The following is a description of a gene set: Hepatoblastoma, the most common pediatric liver cancer, is tightly linked to excessive Wnt/beta-catenin signaling. Here, we used microarray analysis to identify two tumor subclasses resembling distinct phases of liver development and a discriminating 16-gene signature. beta-catenin activated different transcriptional programs in the two tumor types, with distinctive expression of hepatic stem/progenitor markers in immature tumors. This highly proliferating subclass was typified by gains of chromosomes 8q and 2p and upregulated Myc signaling. Myc-induced hepatoblastoma-like tumors in mice strikingly resembled the human immature subtype, and Myc downregulation in hepatoblastoma cells impaired tumorigenesis in vivo. Remarkably, the 16-gene signature discriminated invasive and metastatic hepatoblastomas and predicted prognosis with high accuracy. species: Homo sapiens from publication Cairo S, Armengol C, De Reyniès A, Wei Y, Thomas E, Renard CA, Goga A, Balakrishnan A, Semeraro M, Gresh L, Pontoglio M, Strick-Marchand H, Levillayer F, Nouet Y, Rickman D, Gauthier F, Branchereau S, Brugières L, Laithier V, Bouvier R, Boman F, Basso G, Michiels JF, Hofman P, Arbez-Gindre F, Jouan H, Rousselet-Chapeau MC, Berrebi D, Marcellin L, Plenat F, Zachar D, Joubert M, Selves J, Pasquier D, Bioulac-Sage P, Grotzer M, Childs M, Fabre M, Buendia MA (PMID 19061838) Human Gene Set: CAIRO_HEPATOBLASTOMA_CLASSES_UP Genes up-regulated in robust Cluster 2 (rC2) of hepatoblastoma samples compared to those in the robust Cluster 1 (rC1)., and this is the list of marker genes: OXA1L, DCP2, RPL23, RUVBL2, EIF4E2, AK4, DNAJC4, PQBP1, POLR3E, SLC25A3, BSG, CCT3, POLD1, CERS6, PAXIP1, TUBG1, DNAAF5, NLE1, HNRNPA3P1, SMARCC1, PDIA6, PUS7, DDX18, SNHG14, PABPC4, EIF3H, SEC61G, RFXANK, KIF20A, UTP18, CCNA2, MEP1A, PFAS, R3HDM1, P3H4, B9D1 (B9 domain containing 1), CCT4, IPO5, PUS1, ZC3H15, MCM4, COPS5, RPS21, CSE1L, CKS2, CLNS1A, AGBL5, CHEK1, EIF3F, PSMF1, WDR3, LRRC59, SF3A1, ARFGEF1, CSNK2B, HMGA2, TRAP1, IL1RAPL1, MNAT1, TOMM70, VTI1B, YBX3, MRPS7, PRMT1, NSD2, BORA, PARP1, SNRPB, TCERG1, LANCL2, NUP210, EXOSC4, DNAJC7, GPS1 (G protein pathway suppressor 1), AHCY, NME2, SMC2, TRRAP, GCFC2, HDAC2, CREB3L2, FAM136A, TTK, NAT10, ZNF696, ESF1, GCN1, TPI1, CALU, SRP72, OSBPL2, ENY2, TSR1, PDGFRL, SAP130, CPNE1, PUF60, LRPPRC, ACKR3, HJURP, CDCA4, XRCC6, UNC93A, WDR77, MYL6B, SEC23IP, AURKB, RBM12, TWNK, RPS16, OIP5, SPTLC2, DAZAP1, MCM2, ARMC9, TRIM28, ADISSP, KIF11, PLK1 (NCBI Gene Id 5347), POLR1C, BZW2, TASP1, C1QBP, SMARCA4, STOML2, BUB1B, TRMU, SLC39A4, BUB1, E2F5, EIF3B, TOMM34, LRRC1, CD164, RBM4, SSR3, FAM216A (NCBI Gene Id 29902), ATIC, RCC1, CCT5, ACTR3B, DNAJC10, SNTB1, NOL7, AARS1 (alanyl-tRNA synthetase 1), FARSA, MCM7, CCNB1IP1, MAPKAPK5, DDC, NCBP2, EEF1D, NONO, GTF3C3, RACK1, CCT7, GTF3C2, NHP2, SF3B3, WDR12, UBAP2, STK25, EIF3E, CCNF, ILF3, NUSAP1, RPL14, SEPTIN9, SMC4, EMG1, PPA1, SINHCAF, VARS1, VRK1, UTP20, CDC20, CENPQ, PTK2, FKBP10, POMK, AMD1, DARS1, GMPR2, SAE1, PSMG1, EIF5B, HSPD1, RPL22 (NCBI Gene Id 65281), GART, AGPS, SFI1, GINS2, PRDX4, NME1, SPAG5, HNRNPC, ADSL, AP1G2, MCM6, PRPF6, CCT2, THOC5, KRT19, CENPA, DOP1B, YEATS2, SERBP1, NR2F6, TBC1D31, RPL5, HMMR, CKAP5, AURKA, NDC1, MAZ, TCEA1, PCM1 (NCBI Gene Id 5108), ATP2B1, CDK1, MAPRE1, DMAC2, MRS2, KDELR1, AGPAT5, TBL2, ODC1, FXR1, HOMER1, ALDH18A1, CCDC47, PNKP, NELFE, TMEM97, MAD2L1, SUPT16H, CEP57, PYGL, NPM1, PDIA4, CDKN3 (cyclin dependent kinase inhibitor 3), LAPTM4B, MSH2, BRCA2, FXN, THAP4 (THAP domain containing 4), MDN1, RIOK3, CENPF, PHB2, IPO7, EEF1B2, PHB1, DDX1, MAVS, NOLC1, PLTP, EXOSC2, PDCD4, MSH6, TEX2, TOP2A, TGS1, MTA1, RB1CC1, EIF2S2, UGGT2, SRSF1, FBL, NOP56, RPL6, TBRG4, CANX, DGKD, MYBBP1A, CENPI, ORC4, HSP90AB1 (NCBI Gene Id 3326), RPL28, MLST8, DNMT3A, KIF2C, HSF1, TOMM20, RXYLT1, AIRIM, UTP6, TRIP13, MRPL15, FOCAD (NCBI Gene Id 54914), AFP, TCAF1, EPRS1, HNRNPR, ACP1, ZFR, UQCRB, MCM3, RFC1, MEAK7, DDX27, KNTC1, RTRAF, RPL8, EEF1E1, UBXN8, CIAPIN1, AATF, FBXO5, UTP14A, PMS1, DLGAP5, ERGIC3, GPX7, KARS1, CRELD1, RPL10A (ribosomal protein L10a), KDM1A, HSPA13, UBE2V1, NAE1, PDSS1, YWHAZ, PLIN3, MIF, RPL4 (NCBI Gene Id 6124), RNF126, JPT2, MMS19, RPL18A, ATP6V1H, RPLP0, CCNB2, IMPDH2, AP2B1, COG5, CKLF, MTDH, MRPL12, RRS1, CBX3, RPS14, CHAF1A, COIL, HMGA1, CCT6A, CDKAL1, BOP1, CCDC88A, RPP40, NEK2, CDT1, DDX56, LIG3 (NCBI Gene Id 3980), SOAT2 (NCBI Gene Id 8435), DDX39A, BLMH, HDLBP, CCNE1 (NCBI Gene Id 898), ZNHIT3, RANBP1, PTDSS1, KIF4A, RPS6KB1, RPS3, CDC25C, PIK3C2G, KIF23, RRM2, IARS1, DDX42, EIF4B, MAN1B1, RPL19, UBE2S, ECT2, DNAJC9, BIRC5, ARID3A, DTL, CYC1, SCRIB, CDC27, NT5DC2, DKC1, CHD7, USP24, PSMB5, RPS8, OLA1, GINS1, KPNA2, KIF15, NCL, POLR3D, CENPN, TAF9, TIMM9, CHEK2, EIF3M, ANGEL1, RPS6 (NCBI Gene Id 92956), PTPRA, CDK4, ATP5MC2, CPSF1, ENO1, BFAR, QARS1, KIAA0930, PNO1, CCNB1, JPT1, CSNK2A1, SRSF2, MAD1L1, HTRA2, KLHL7, KIF22, GLDC, PDCD11, SRSF9, NUP153, CDC25A, PRMT3, POP7, RAB4A, COMMD8, UQCRH, TAF1D, TAF12, HNRNPA3, FANCI, TDP1, NIP7, LSM2, NUP205, CIZ1, NUP85, ODF2, CAPRIN1, KIF14, SKP2, LSP1P5, ECPAS, HIC2, MRTO4, PRKDC, CPSF6, TPGS2, AARSD1, PSPH, RFWD3, SMARCB1, SNU13, YBX1, DGUOK, PPAT, SNRPD1, CAD, CNOT6, SLCO4C1, MIS18A, RRM1, AGFG1, ENOPH1, DPH5, BCCIP, KIF18B, ST13, METTL8, THG1L, ASPM, GRK6, RSL1D1, RPL37A, WARS2, RNASEH2A, TPD52L2, SNHG32, APRT (adenine phosphoribosyltransferase), XRCC5, TMPO, GINS4, ATP6AP1, DBF4, NUP93, DLST, GGCT (NCBI Gene Id 79017), LDAH, NCAPG2, DDOST, SFPQ, PLCXD1, MRPS27, RUVBL1, RFC4, CIAO1, ACSL3, MRPS33 (NCBI Gene Id 65515), APEX1, GPN1, PRDX6, SUPT3H, VDAC2, C8orf33, PI4KA, HEATR1, KPNB1, RPL18, TMA16, EIF4A1, AAMP, USP10, NTAQ1, CTSV, SMARCA1, LIG1, FKBP1B (FKBP prolyl isomerase 1B), RAN, HMGB2, SLCO4A1, GNL3, SNX5, RPN2, FASTKD1, ZWILCH, TFRC, HMGB3, HS2ST1, IPO4, DNMT1, EIF4A3, LSM4, SRPK1, EIF2B4, DTYMK, NOP16, TIMELESS, ZNF207, EPCAM, PRMT5, MRE11, MKI67, DUSP9 (NCBI Gene Id 1852), EZH2, SPDL1, GCSH, NPM3, NDC80, BYSL, RABGGTB, NCAPG, BUB3, SNRNP200, IMP4, PUDP, CDC6 (cell division cycle 6), NUFIP1, RPL11, MCM10, SQLE (NCBI Gene Id 6713), MRPS18B, ILF2, ABCF2, KIF18A, P4HB, NOL11, LYRM4, RPL36, SSRP1, KMT5AP1, PTP4A3 (NCBI Gene Id 11156), SUPT4H1, PBK, NCAPD2, LTA4H, U2SURP, FNTA, DDX41, EIF3L, RFC2, HUWE1, NCLN, FANCA, RPS9, TPX2, UBE2C, IGSF1, MPZL1, XPO7, RPL24 (NCBI Gene Id 6152), GTF2F1, CDCA8, SSB, SLC35F5, TXNL4A, RAD51AP1, RPL15, CHCHD2, ACLY, MYCBP, GTPBP4, PPP1CC, DDX10, SULT1C2, WDR46, CLIC1, POLR2D, PRC1, MYCN, RBX1, UPK3A (uroplakin 3A)